Given this list of marker genes H2BC21, KLKB1, H2AC14, H2BC17, H2AX, H2BC3, H2BC15, H2BC12L, H2AC6, PRCP, H2AC7, H2BC13, H2BC14, H2BC5, HRG, C1QBP, F12, H2BC26, H2AB1, PLAUR, H2BC9, H2AC20, H2BC1, A2M, H2BC12, H3C1, H3-3A, H2AZ1, SERPING1, KNG1, H4C1, H2AC18, H2BC4, H3C15, KRT1, H2BC11, H2AC4, here is a description of the gene set: part of: Innate Immune System Reactome Pathway: FXIIa activates plasma kallikrein-kinin system studied in species Homo sapiens The plasma kallikrein-kinin system (KKS) is a proteolytic cascade that regulates vascular homeostasis and inflammatory signaling through the generation of vasoactive kinin peptides such as bradykinin (BK) (Motta G et al., 1998; Zhao Y et al., 2001; Schmaier AH, 2016; Palarasah Y et al., 2022; Motta G et al., 2023). Activation of the plasma KKS leads to the proteolytic conversion of plasma prekallikrein (PK zymogen, encoded by KLKB1) into active plasma kallikrein (PKa)), a serine protease that cleaves various substrates, including high-molecular-weight kininogen (HK, encoded by KNG1 and depicted here as KNG1(19 644)). PKa-mediated cleavage of HK releases BK (depicted here as KNG1(381-389)), the primary effector peptide of the plasma KKS pathway (Pinheiro AS et al., 2022). BK binds constitutively expressed B2 receptors (B2R, encoded by the BDKRB2 gene) to induce vasodilation, increased vascular permeability, smooth muscle contraction, and pain signaling. C-terminal Arg residue removal generates des-Arg⁹-bradykinin, which activates the inducible B1 receptor (B1R, encoded by the BDKRB1 gene) upregulated during inflammation (Prat A et al., 2000; Lau J et al., 2020; Othman R et al., 2021). Receptor expression is dynamically regulated by inflammatory stimuli and components of contact act activation system (CAS) and KKS. The bradykinin receptors form homodimers and heterodimers with themselves and with multiple G-protein coupled receptors of renin-angiotensin system, including angiotensin I receptor (AT1R), AT2R, and MasR, creating integrated signaling networks (Cerrato BD et al., 2016; Bekassy Z et al., 2022). Furthermore, 40% of BK is metabolized by binding to the B2R receptor by receptor-mediated uptake. This pathway is in part caveolin-mediated. Additionally, bradykinin signaling is tightly controlled by multiple bradykininases, that degrade the peptide at its amino-, carboxy-terminal ends and in between (Pinheiro AS et al., 2022). The angiotensin-converting enzyme (ACE, kininase II) is the major plasma bradykininase. Some bradykininases (e.g., carboxypeptidase M) form functional heterodimers with the bradykinin B1 receptor, serving as allosteric modulators (Zhang X et al., 2013; Guimarães PB et al., 2019).<p>When activation of plasma kallikrein occurs as a step in the contact activation system (CAS), it is catalyzed by activated factor XIIa (FXIIa), itself generated by the proteolytic cleavage of the FXII zymogen (Hageman factor, encoded by F12) (Samuel M et al., 1992; Shamanaev A, Ivanov I et al., 2022) upon binding to negatively charged surfaces, e.g., biological products, such as DNA, RNA, phospholipids, collagen, extracellular vesicles or artificial entities like kaolin, lipid nanoparticles, silica, celite, etc.. Surface binding induces a conformational change that exposes the catalytic domain, allowing autoactivation or plasma kallikrein-mediated cleavage of FXII to FXIIa, which consists of a heavy chain (20-372) and a light chain (373-615) held together by disulfide bonds (Samuel M et al. 1992; Shamanaev A, Ivanov I et al. 2022; reviewed by Shamanaev A, Litvak M, Gailani D 2022). The serine protease activity of FXIIa then activates its substrates, including plasma prekallikrein (PK) (Ivanov I et al. 2017; Shamanaev A, Ivanov I et al. 2022). Activated PKa, in turn, reciprocally activates more FXII, establishing a positive, amplifying, feedback loop (de Maat S et al., 2019; reviewed in Long AT et al., 2016; Schmaier AH 2016). While these reciprocal cleavage reactions can occur in solution, they are significantly accelerated when FXII and PK bind to a surface in the presence of Zn²⁺. <p>High-molecular-weight kininogen (HK, KNG1(19 644)) is a plasma protein that facilitates the interaction and reciprocal activation of prekallikrein and FXII on surfaces (Thompson RE et al., 1979; Renné T et al., 2002). Domain 6 (D6) of HK mediates binding to PK (Thompson RE et al., 1979; Tait JF & Fujikawa K, 1987), while domain 5 binds Zn²⁺ and negatively charged surfaces, such as glycosaminoglycans (GAGs) (DeLa Cadena RA & Colman RW, 1992; Herwald H et al., 2001). In addition to GAGs, HK can bind to cell surface receptors, complement C1q binding protein (C1QBP, also known as globular C1q receptor or gC1qR), urokinase plasminogen activator receptor (uPAR, encoded by the PLAUR gene), and cytokeratin 1 (CK1, encoded by the KRT1 gene) (Hasan A et al, 1998, Colman RW et. al, 1997, Joseph K et al. 1996, 2001; Herwald H et al. 1996; Mahdi F et al., 2002; Kaira BG et al., 2020; Stavrou EX et al., 2018). For instance, HK binding to C1QBP facilitates the assembly of HK, PK, and FXII into higher order ternary complexes, where FXII and PK reciprocally activate each other in a Zn²⁺ dependent manner (Joseph K et al., 1996, 1999, 2001, 2004; Kaira BG et al., 2020). <p>Physiologically, the kallikrein kinin system is primarily activated on endothelial cell surfaces (Lin Y et al., 1997; Motta G et al., 1998; Joseph K et al., 2001; Mahdi F et al., 2003). Although FXII binds endothelial cells, the binding alone is insufficient for activation. FXII can remain bound to cultured endothelial cells for up to 2 hours without being activated; the presence of HK and PK is required to trigger rapid conversion to FXIIa on endothelial surfaces (Merkulova AA et al., 2023). Other cell types may contribute to KKS activation by exposing negatively charged surfaces such as polyphosphate chains in activated platelets (Verhoef JJF et al., 2017), phosphatidylserine on apoptotic T-lymphoblast cells (Yang A et al., 2017) or expressing relevant receptors.<p>Importantly, PK activation on endothelial cells can also occur via S28 serine protease prolylcarboxypeptidase (PRCP) independently of FXIIa. PRCP was initially characterized as an endopeptidase because it cleaves C-terminal Pro-X bonds, as in bradykinin, generating des-Arg⁹-bradykinin. It also metabolizes the C-terminal Pro-Val bond of α-melanocyte–stimulating hormone (α-MSH1–13) (Wallingford N et al., 2009). Using classical biochemical approaches, a serine protease that activated PK when bound to HK on cultured endothelial cells was isolated and identified as PRCP (Shariat-Madar Z et al., 2002). Recombinant PRCP exhibits identical properties to the native enzyme isolated from plasma (Shariat-Madar Z et al., 2004). Finally, downregulation of PRCP by siRNA and upregulation by PRCP transfection directly regulate PK activation on endothelial cells (Shariat-Madar Z et al., 2005; Merkulova AA et al., 2023).<p>Beyond its role as an endopeptidase and PK activator, PRCP has defined physiological activities. PRCP gene-trap mice (Prcp gt/gt) are hypertensive and prothrombotic in injured arteries (Adams GN et al., 2011). PRCP exhibits growth factor properties, stimulating endothelial cell growth and proliferation (Adams GN et al., 2013). Following ischemia-reperfusion injury, Prcp gt/gt mice are protected from neointimal cell growth and proliferation, whereas PRCP promotes vascular repair and neoangiogenesis after vessel wall injury.<p>Activated FXIIa and PKa coordinate multiple pathways. Plasma kallikrein mediated cleavage of complement component C3 (Irmscher S et al., 2018) and FXIIa mediated cleavage of C1 trigger the complement activation (Ghebrehiwet B et al., 1981). FXIIa also promotes fibrin clot formation by activating FXI on the cell surface (Cheng Q et al., 2010), while plasma kallikrein directly binds and activates FIX (Visser M et al., 2020; Kearney KJ et al., 2021).